The following is a description of a gene set: Genes down-regulated in CD8 T effector cells during chronic infection with LCMV-Clone 13: day 8 versus day 15. from publication Doering TA, Crawford A, Angelosanto JM, Paley MA, Ziegler CG, Wherry EJ (PMID 23159438) species: Homo sapiens Human Gene Set: GSE41867_DAY8_VS_DAY15_LCMV_CLONE13_EFFECTOR_CD8_TCELL_DN During acute viral infections, naïve CD8+ T cells differentiate into effector CD8+ T cells and, after viral control, into memory CD8+ T cells. Memory CD8+ T cells are highly functional, proliferate rapidly upon reinfection and persist long-term without antigen. In contrast, during chronic infections, CD8+ T cells become “exhausted” and have poor effector function, express multiple inhibitory receptors, possess low proliferative capacity, and cannot persist without antigen. To compare the development of functional memory T cells with poorly functional exhausted T cells, we generated longitudinal transcriptional profiles for each., and this is the list of marker genes: OCIAD2, GZMH, RPS19BP1, KCTD1, GALE, FAF1, OVCA2, FARP2, EVA1B, EME1, TAMM41, EIF3K, BLMH, HSD17B7, MVD, CLEC4E, TRIM37, MCM8, TLCD1, ATP11A, SHCBP1, CKAP2L, SV2A, OTULIN, MVK, MAP4, NXN, NUP93, INHBA, DTYMK, NDUFS6, ZFYVE19, ERI2, SOCS2, CCDC90B, WDR26, ALAS1, PSMD9, BTF3, WDR7, KLHDC1, ABCB6 (NCBI Gene Id 541461), RPP14, SNRPD1, LPP-AS2, TMEM263, HOOK2, MRPL9, YARS1, DAP3, EIF1AX, CKAP2, TRAPPC6A, CCDC162P, TYW3, REXO2, ATF5, ALG5, DRG1, NAA25, IGBP1, STX12, C8orf76, MRPL11, LIN37, GSTT1, PIN4, TDP1, POLE3, MKKS, VPS29, MID1IP1, POLR1D, NIT2 (NCBI Gene Id 56954), WDR76, PSMC6, RNF5, GOLGA7, SIKE1, GPI, NDUFB3, BBS10, UCHL3, TIMM23, C1orf131, LDHA, LCMT1, ENKD1 (enkurin domain containing 1), MAP3K20, ZNF708, NCBP2AS2, ACTR3B, CMAS, CCDC127, EPRS1, PRPF31, POLR3K, SGCB (sarcoglycan beta), NSDHL, DDX1, CD320, NDUFA2, MIS18BP1, DBR1, RNF168, POLD2, CDC123, HMGA2, DUSP19, G2E3, EBI3, RAB19, ACSL5 (NCBI Gene Id 51703), PIGF, RGS12 (NCBI Gene Id 6002), VNN1, EIF3D, WARS1, TIMM50, CDC45, SCLY, NUP133, NPAT, NCEH1, CENPM, TOMM40, MRPL10, MRPL15, ACTA1, CDC25C, TEKT3, PRELID3B, ULBP1, DERA, GLMN, COX6A2, ZCCHC17 (NCBI Gene Id 95373), DFFB, MED8, NSMCE1, MAP2K2, STOML2, KNL1, PLK4, PSMC1, UPP1, CBX3, MARS1, FKBP2, PUS10, COPS2, SNAPC2, NCBP3 (nuclear cap binding subunit 3), TIPRL, WIPF1, SARNP, MCEE, SANBR, STARD4, IFT25, IRF9, EFCAB14, IFIT1, NANS, HDAC3, EXOG, VIPAS39, DHRS7B, THOC3, RPN2, MRPL57, GLOD4, NUCKS1, GPHN, COQ3, TNNT1, DCTN2 (NCBI Gene Id 1640), ANXA7, PPP1R14B, MALSU1, NDUFA5, GNPAT, RIOX1, NMT1, CYP51A1, MED9, ZNHIT2 (zinc finger HIT-type containing 2), DCXR, NDUFS8, GSN, GCA, SEH1L, IPO11, MAPRE2 (microtubule associated protein RP/EB family member 2), SNX29 (sorting nexin 29), QPCT, IAH1, NDUFA7, RBM12, HTR7